Given this list of marker genes EIF5A2, DOHH (deoxyhypusine hydroxylase), DHPS, EIF5A, here is a description of the gene set: part of: Gamma carboxylation, hypusinylation, hydroxylation, and arylsulfatase activation studied in species Homo sapiens Cytosolic eukaryotic translation initiation factor 5A (eIF5A) undergoes a unique two-step post-translational modification at Lys 50 via deoxyhypusine (Dhp) to hypusine (Hyp). In the first step deoxyhypusine synthase transfers the aminobutyl group of spermidine to the epsilon-amino group of lysine 50, using NAD+ as a cofactor. Hydroxylation of the C2 of the newly added moiety in the second step is catalyzed by deoxyhypusine hydroxylase/monooxygenase with molecular oxygen as the source. The molecular function of eIF5A is unknown, but the protein is required for viability in eukaryotic cells and its normal function requires hypusinylation. eIF5A is the only protein known to undergo hypusinylation. Reactome Pathway: Hypusine synthesis from eIF5A-lysine